The following is a description of a gene set: Removal of the transcription factor SAP1a member of the Ternary Complex Factor (TCF) group of transcription factors which in conjunction with Serum Response Factor (SRF) has been shown to have a profound effect on positive selection in the thymus. When another TCF Elk1 is knocked out in mice there is no effect on positive selection unless it is on a Sap1a KO background where the phenotype is very severe. We have stimulated isolated double positive T cells (DPs) with anti-CD3 to mimic positive selection and compared basal and stimulated transcription across the four genotypes to discover the downstream targets of Sap1a involved in positive selection. Genes up-regulated in untreated double positive thymocytes: wildtype versus ELK1 knockout. studied in species Homo sapiens Human Gene Set: GSE21546_WT_VS_ELK1_KO_DP_THYMOCYTES_UP from publication Costello P, Nicolas R, Willoughby J, Wasylyk B, Nordheim A, Treisman R (PMID 20554967), and this is the list of marker genes: ARHGAP6, IL31RA, PLEKHA6, FLOT1, COPRS, CCDC40, ADARB2, COG4, G6PD, ACER3, ATP6V0A1, P3H1, SARAF, NME8, GET1, IKZF2, GCNT1, TMUB1, SYNGR2, HSPBAP1, DLX3, COL1A2, SIX5, NTPCR, BAHCC1, LETMD1, LMF1, LIPT2, NRXN1, CRYZ, MCEE, RPS10, DCTN6, TCEA2, FAM120C, VKORC1, CHEK2, SYCE2, INTS9, NOTCH2, R3HDM4 (R3H domain containing 4), ZNF839, TRPV2, MAFG, HSD3B7, ABHD11, ST8SIA5, GALNT6, FKBPL, TMC8, ABCC4, KCTD14, ZNF395, EEF1B2, GSTO1, MANBA, GYG1, RPL32, VAMP8, HARBI1, AAMDC, RPS23, GPX1, YBX3, IRF7, ABHD4, ADCY7, DMAC2, RNF149, EEF1AKMT1, FDX1, PTGER3, LDHC, MYOZ3 (NCBI Gene Id 91977), PCNX2, ZNF205, CHST11, COMP, ATG9B, DIPK1A, DOCK5, TUSC1, HYAL2, VWA3A, DSP, SAMHD1, VPS37B, WASF3 (WASP family member 3), TBC1D24, NPRL3, TPRA1, RGS18, LMBR1, SSC5D, CD44, SERPINE2, GSTA3, C15orf61, XRCC2, ORAI3, FOXO4, GNG12, CDK10, MED22, TADA3, NKX2-6, QPRT, MRPL48, MIDEAS, PEX11A, LMAN2, GDE1, NLGN1, GSS, IRAK2, FADD, ABCA2, ABCC1, SLC22A14, ST6GALNAC4, CTSF, ANGPT1, CTBP2, FRMD4A, PTER, STX3 (syntaxin 3), FAM168A, CLN6, TOR1B, TNS1, SUOX, DDX4, ZNF623, TPK1 (NCBI Gene Id 27010), SARS2, CLEC3B, SMOX, RAB38, KLHDC2, TMBIM1, UNC13D, ANKH, ADAM17, SGSM2, PSPN, SYNJ1, MACROD1, SLC10A3, ZBTB16 (zinc finger and BTB domain containing 16), SPNS2, HNMT, GAA, OAS2, AMH, NINL, RBM45, DRD4, SVIP, RSAD2, OMA1, SLC22A4, MMP17, C19orf48P, DDHD2, NFE2, SMO, ABHD16A, SSR4, CTTN, FOS, MESP1, TMEM204, VPS26B (NCBI Gene Id 112936), SETD4, STK19, CXCL6, TMEM87A, MPP7, FRRS1, OTP, AAMP, GDPD3, MID1, RSAD1, RPL10, RAB37, GP9, IRF9, SLC39A11, ZBTB45 (zinc finger and BTB domain containing 45), TTC3 (NCBI Gene Id 7267), VEGFB, TMEM40, STK32B, IMMP2L, BTNL9, EXOC6, NIBAN2, CD8B